Given this list of marker genes GBP3, NINJ2, GBP7, RNASE7, CCL28, GBP5, HMSD (histocompatibility minor serpin domain containing), GBP1, NINJ1, GBP2, CAMP, here is a description of the gene set: The rupture of cell membranes and the loss of cytoplasm. species: Homo sapiens Human Gene Set: GOBP_CYTOLYSIS